Given this list of marker genes Hcrt, Penk, Serpini1, Adcyap1, Zp3r, Spata31, Crh, Prss57, Grp, Pcsk1, Igf1, Spaca7 (sperm acrosome associated 7), Dbh, Ins2, Prtn3, Gip, Pcsk2, Ghrl, Gcg, Ins1, Vps13a, Pdyn, here is a description of the gene set: Mouse Gene Set: GOCC_SECRETORY_GRANULE_LUMEN species: Mus musculus The volume enclosed by the membrane of a secretory granule.